The following is a description of a gene set: This event has been computationally inferred from an event that has been demonstrated in another species.<p>The inference is based on the homology mapping from PANTHER. Briefly, reactions for which all involved PhysicalEntities (in input, output and catalyst) have a mapped orthologue/paralogue (for complexes at least 75% of components must have a mapping) are inferred to the other species. part of: Complement cascade Reactome Pathway: Activation of C3 and C5 studied in species Mus musculus electronically inferred by orthology from the curated human pathway, and this is the list of marker genes: C3, C2, Cfp, C4b, Hc